Given this list of marker genes ABCG5, ENPP1, HGD, LDLR, GATA5, ERCC6, RNASEH2A, STAT1, ERCC8, NT5E, ABCG8 (ATP binding cassette subfamily G member 8), NKX2-5, RNASEH2C, IFIH1 (interferon induced with helicase C domain 1), ABCC6, ADAR, SLC20A2, LDLRAP1, RNU7-1, APOB, GALNT3, RNASEH2B, PDGFRB, PDGFB, SAMHD1, NOTCH1, PCSK9, SLC34A2, LSM11, GBA1, TREX1, SMAD6 (SMAD family member 6), here is a description of the gene set: Abnormal calcification of the vasculature. studied in species Homo sapiens Vascular calcification Human Gene Set: HP_VASCULAR_CALCIFICATION